The following is a description of a gene set: Mouse Gene Set: ZFP268_TARGET_GENES studied in species Mus musculus from publication Yevshin I, Sharipov R, Kolmykov S, Kondrakhin Y, Kolpakov F (PMID 30445619), and this is the list of marker genes: Gprin1, Gm12501, Cacng2, Barhl1, Glra1, Scrt1